The following is a description of a gene set: Mouse Gene Set: MP_INCREASED_LUNG_TUMOR_INCIDENCE Mouse genes annotated to increased lung tumor incidence (MP:0008014) retrieved from the Mouse Genome Informatics database via MouseMine from publication Motenko H, Neuhauser SB, O'Keefe M, Richardson JE (PMID 26092688) species: Mus musculus, and this is the list of marker genes: Fgf9, Tom1l2, Psmb9, Rb1, Nkx2-9, Pold1, Hace1, S1pr2, Btg3, Cbx7, Men1, Bub1, Wwox, Chuk, Trp53, Cdkn2c, Spry2, Fzr1, Pinx1, Braf, Cul9, Xpc, Usp24, Gprc5a, Ppp2r1a, Msh2, Sirt2, Plk3, Pole, Mapk14 (NCBI Gene Id 26416), Dok2, Tsc2, Smad4, Fen1, Kras